Given this list of marker genes RAD52, HELQ, SLX1A, SLX1B, RBBP8, RNF138, OGG1, SLX4, here is a description of the gene set: Repair of a DSB made between two repeated sequences oriented in the same direction occurs primarily by the single strand annealing pathway. The ends of the break are processed by a 5' to 3' exonuclease, exposing complementary single-strand regions of the direct repeats that can anneal, resulting in a deletion of the unique DNA between the direct repeats. Human Gene Set: GOBP_DOUBLE_STRAND_BREAK_REPAIR_VIA_SINGLE_STRAND_ANNEALING species: Homo sapiens